Given this list of marker genes Adar, Coro1c (coronin, actin binding protein 1C), Dusp10, Npm1, Errfi1, Cdk5rap3, Adarb1, Garem1, Ppm1f, Pten, here is a description of the gene set: Mouse Gene Set: GOBP_NEGATIVE_REGULATION_OF_PROTEIN_KINASE_ACTIVITY_BY_REGULATION_OF_PROTEIN_PHOSPHORYLATION studied in species Mus musculus The stopping, prevention, or reduction in frequency, rate or extent of protein kinase activity as a result of regulating the phosphorylation status of that protein kinase.